Given this list of marker genes GATA3 (NCBI Gene Id 84828), SLCO1C1, HPN, DUOXA2, DUOXA1, PAX8, here is a description of the gene set: Any process that modulates the frequency, rate or extent of thyroid hormone generation. Human Gene Set: GOBP_REGULATION_OF_THYROID_HORMONE_GENERATION species: Homo sapiens